The following is a description of a gene set: species: Mus musculus Any process that modulates the establishment or extent of a resting potential, the electrical charge across the plasma membrane, with the interior of the cell negative with respect to the exterior. The resting potential is the membrane potential of a cell that is not stimulated to be depolarized or hyperpolarized. Mouse Gene Set: GOBP_REGULATION_OF_RESTING_MEMBRANE_POTENTIAL, and this is the list of marker genes: Kcnk6, Kcnj10, Kcnk9, Nalcn, Cntf, Psen1, Clcn2, Trem2, Kcnk13, Kcnk1, Kcnk3